Given this list of marker genes SERPINH1, TCIRG1, SOCS3, MGLL, CYP1B1, RGS2, PSMB9, IL4R, MFAP4, ACP5, PLIN2, JUNB, TGFB1, APOC1, IGHG3, POSTN, CD53, NEDD9, CLDN5, SFTPD, DUSP6, TIMP2, WIF1, SRGN, AQP1, TACSTD2, COL1A2, COX7A1, TLR2, ITGB2, ENG, RNASE1, RGS5, NOTCH3, C7, MSMO1, CYP4B1, TGFBR3, APRT, CCL18, LIPA, ANGPT1, INSIG1, C1QB, ITGAM, LMO3, TPSAB1, CITED2, NNMT, EMILIN1, PLEC, DMBT1, SLIT2, DEFA3 (defensin alpha 3), CCL2, SLC39A8, TPM2, GRK5, GYG1, CSF3R, C1S, MAP2K3, CCL15, ADM, CD37, CDC42EP1, MAGI1, LPXN, LIMK2, CXCL8, TSPAN3, SFTPB, ASAH1, GPRC5A, LYN, CX3CL1 (C-X3-C motif chemokine ligand 1), STAB1, NAMPT, LCP1, ANXA4, UGCG, GLRX, DEPP1, MTUS1, PIM1, FABP4, S100A9, UBE2L6, ADGRE5, CAV2, SLPI, THBS1, QSOX1, IL1RN, NDUFB7, CD44, CYP2B6, SNRK, SELENOP, HPGD (NCBI Gene Id 3248), TGM2, CAVIN1 (NCBI Gene Id 284119), LDB2, WFS1, TEK, MARCO, MVP, SERPINA1, FCN1, MEGF9, GPSM3, VAMP5, PTPRC, RARRES2, DLC1, CHI3L2 (NCBI Gene Id 9155), KRT18, SELL, CADM1, CD55, CYP27A1 (cytochrome P450 family 27 subfamily A member 1), IER3, DTX4, WFDC2, PLXND1, AIF1, PDGFRB, HES1, LAPTM5, SNX1, PDXK, RNF167, C2, GPX3, MNDA, LUM, MSLN, VWF, LILRB3, RBPMS, CES1, PPP1R15A, ACP2, ANXA1, CDKN1A, FGFR4, ABLIM1, SDC1, AGR2, IL7R, HPR, PRB4, NRGN, IFI16, HCK, APOD, LAIR1, RFTN1, RAC2, SLCO2B1, PTP4A3, CAV1, FBP1, ANOS1, PLAAT4, IRF1, IGHM, S100P, STAT3, MMP9, CRYAB, ALCAM, IGFBP6, FCGR3A, TNFRSF14, ITGA6, S100A11, RHOB, GPNMB, CFD, NKX2-1, F3, ALAS1, DDX21, LTBP2, TBX2, SLC7A7, EPCAM, LDLR, RHOG, CALD1, LAMA5, LMO2, VCAN, ARHGAP4, IL1B, CLEC3B, FADS1, ADH1B, PLSCR1, CALCRL, RAB5C, PCOLCE, TSPAN1, FBLN1, CRIP1, SEC11A, SECTM1, PTPRK, TNFRSF1B, DNM2, SEPTIN10P1, COL6A1, PGC, MUC1, ECHS1, TNFAIP2, DEFB4A, ADAM19, EPAS1, HEG1, TSPAN7, PALM2AKAP2, PIK3C2B, IFNGR1, WWTR1, ACSL1, LGALS9, TAP1, ITPR3, FCGR2A, ITGB5, HLA-DQA1, COL4A1, ACTN1 (NCBI Gene Id 87), COL6A2, MAPKAPK3, CCN5, ZYX, LCP2, CCL5, IL32, MX1, MAOB, PCDH17 (protocadherin 17), PON2, LCN2, CD52, CD302, JCHAIN, ICAM1, CCND1, MRC1, GATA2, ADIPOR2, CLEC2B, FGFR1, GBP1, TIMP3, LAMP3, CYB5A, HMOX1, IL13RA1, PTX3, RPS6KA1, CNN3, NEBL, SCNN1A, RAMP2, S100A4, LRRC32 (leucine rich repeat containing 32), GNG11, COL3A1, ADH1C, ENPP2, ST6GALNAC4, DHRS3, MYO1B, EFNA1, MAL, AGER, TNFAIP3, CDA, IL2RG, ABCA3, FGR, HCLS1, CEACAM6, TGFBR2, G0S2, SFTPC, RAB31, BIRC2, TM4SF1, TGFBI, ARHGDIB, CRIM1, CMAHP, WAS, CLDN7, SRPX, KRT19, RRAS, ACKR1, ETS2, MAOA, CTSA, SERPINB1, FN1, FOSL2, TBC1D2B, SLA, ALDH1A1, PPL, HLA-DMA, CYB5R1, TFPI, TPM1, CTSC, RBMS1, DPYD, COL6A3, CXCL1, FCGR3B, IFI27, CSF2RB (NCBI Gene Id 3564), LPL, CSRP1 (cysteine and glycine rich protein 1), CAPG, IL6, ID1, HOPX, MYLK, NCF4, HP, GPC3, LPCAT1, IGFBP4, CCR1, TNFSF10, ALPL, ANXA2, HLA-DQB1, ADIRF, AQP3, DAB2, SERPINA3, CORO1A, CST7, TYMP, CXCL2, ITPR1, KLHDC3, S100A8, SLC2A3, EMP2, ORM2, ATP11A, SLC39A7, PPP4R1, CD163, VEGFA, LTBR, IRF9, P4HA2, MALL, AOC3, LST1, FOLR1 (folate receptor alpha), PLAUR, TNC, CDH5, GRN, APOE, PER1, CACNA2D2, MYH11, LGMN, CD151, TNXB, CLDN18, CD14, MAFF, EPB41L3, GJA1, SOD3, DPYSL3, ADH1A, CALU (NCBI Gene Id 813), NKG7, NUPR1, F13A1, SRRM2, PTPN12, CDH11, GMFG, PRR4, CASP4, SCGB1A1, SLC16A3, FUCA1, FSTL3, FLNA, ITGA3, TCEAL4, PDGFRA, VSIG4 (NCBI Gene Id 11326), FCER1G, PECAM1, LAMB2, NR4A1, AQP4, HSPG2, NFIL3, CCL3, FCGRT, STAT1, BLVRB, UPP1, IL1R1, CD34, CYBB, ALOX5, PTGDS, ANXA3, CCN1, BCAM, ALOX5AP, GNS, AP1M1 (NCBI Gene Id 8907), MYL9, KRT7, EMP3, PNP, here is a description of the gene set: Human Gene Set: MODULE_5 species: Homo sapiens Lung genes.